Given this list of marker genes SLC25A15, SLC66A1, SLC25A2, SLC25A29, SLC7A3, SLC66A1LP, SLC7A2, SLC7A1, SLC7A6, here is a description of the gene set: Enables the transfer of L-lysine from one side of a membrane to the other. L-lysine is 2,6-diaminohexanoic acid. Human Gene Set: GOMF_L_LYSINE_TRANSMEMBRANE_TRANSPORTER_ACTIVITY studied in species Homo sapiens